Given this list of marker genes Nfkb1, Dhx9, Myd88, Nfkb2, Irf7, Dhx36, Rela, here is a description of the gene set: species: Mus musculus Mouse Gene Set: REACTOME_DEX_H_BOX_HELICASES_ACTIVATE_TYPE_I_IFN_AND_INFLAMMATORY_CYTOKINES_PRODUCTION DEx/H-box helicases activate type I IFN and inflammatory cytokines production